Given this list of marker genes MAF, DHODH, SOX2, GPC4, TGFBR1, GDF11, RBM8A, RUNX2, TBX6, RPS26, PUF60, SF3B4, MTX2, ANKRD11, ANK1, AFF3, SIX6, SKI, SF3B2, PTCH1, PDGFRB, NIPBL, IFT57, SON, IKBKG, ACTB (NCBI Gene Id 60), GPC3, GATA6, PAX3, here is a description of the gene set: Human Gene Set: HP_SUPERNUMERARY_BONES_OF_THE_AXIAL_SKELETON species: Homo sapiens Supernumerary bones of the axial skeleton